Given this list of marker genes RNF5, STT3B, TSC1, SIRT1, STAT3, MYRF, CCNA2, TRPM2, SAMTOR, JAK3, AHSG, PID1, BLM, CNGA3, EXT1, PIK3R1, FCGR2B (NCBI Gene Id 2213), LY6S, ZFP36L1, ARHGEF2, SEC61B, AQP1, PTPRE, REG3G, LARP1, EGLN1, EZR, AFG2B, CRKL, PLCB1, HDAC9, OGT, SSH1, FBXW8, SLC27A1, ABCC1, EDNRB, PPP1R9B (NCBI Gene Id 84687), CASP6, IRF5, SOCS2, RALB, ADCY6, HSD11B2, CHRNA5, KANK1, C1QTNF12, NPR2, MTOR, GHR, AMFR, RYR1, NUCKS1, ERLIN1, FAM8A1 (family with sequence similarity 8 member A1), CASR, MDM2, GRIN1, KCNJ11, IFNK, AUP1, CHUK, MMP13, XRN1, SOS1, ATF6, MIR200A, ATP5PO, EEF2, RPS6KB2, FABP3, SDF2L1, CTNNB1, CHRM5, NOD2, CEBPA, PLN, IGFBP5, CD9, KCNJ8 (NCBI Gene Id 3764), TGM2, SVIP, IFNA2, APPL1, NPLOC4, TRPV1, GPIHBP1, CDK2, PDE3B, FFAR3, NDUFS4, PKD2, BMP7, CREB1, ALAS1, GRIN2A, TRPA1, PDE12, MBD5, CASTOR2, BTG1, RAPGEF3, ADCY8, CYBB, CARTPT, YWHAG, UBQLN2, TAF1, SLURP2, CSH1, IFNA8, SOX17, PRKCQ, RNF103, TMUB1, PELI1, PCNA, FOSB, CTNNA1, EDEM3, KLF16, NKX6-1, SELENOS, GPER1, TRPM4, EDEM1, IFNA14, AGTRAP, BRCA1, AQP9, HTR1B, TMEM129, PKM, RNFT1, SP1, ZDHHC7, LEP, GABRB1, BCAR1, DNAJB12, FAM114A1, EREG, IRAK3, PPP1R1B, SLC3A2, ATP2B4 (NCBI Gene Id 54594), CDH1, ZNF592, DERL2, HTR2B, GRM5, POMC, MIR140, TFF1, OAS1, IRS1, DPEP1, G6PC1, PLA2G2A, PENK, NEFL, TYK2, CHRM4, TMEM38A, OTOP1, TBC1D4, EEF2K, RGS10 (NCBI Gene Id 6001), FAF1, MAPK14, PRKAA1, INAVA, HCN2, AQP8, CAMK2A, EIF2B1, ATP2B1, RGS2, RANGAP1, CALCR, LRP5, CHRNE, ADTRP, ATF1, MYC, GPRIN3, FBXO2, PDPK1, LYN, SLC27A4, CSRP3, ITGB1, REG1A, WNT1, FKBP5, LPIN3, PDE1B, TRIM72, INS, MIR143, TLR9, PIK3C2A, TSC2, GNRHR, MIR107, REG1B (regenerating family member 1 beta), SGCB, MIR145, EIF4EBP2, RHOQ, FOXO3, RCN3, LCN2, EDN1, ACTB, OPRM1, HTR1A, YOD1, DIAPH1, PPP3CA, RNF185, TMBIM6, FBXO17, STAT2, LIPA, CDK5R1, GAL, CARD9, GNA15, MIR98, FPR2, AP3S1, GRM2, CACNG4 (calcium voltage-gated channel auxiliary subunit gamma 4), TRIM41, MAN1A2, LRP6, HTR2A, INHBA, RNLS, GALP, UBXN10, SRC (SRC proto-oncogene, non-receptor tyrosine kinase), CCL19, RAB10, GPLD1 (NCBI Gene Id 2822), RTF2, NAGK, GCK, CAD, PRKN, UMOD, BACE1, ACE, P2RY6, TOR1A, LY6H, USO1, CACNA1B, HTR3A, GRB7, APLP1, BCL2L1, AHR, AKT1, RYR2, GRB14, ERRFI1, MIR27B, GRB10, SLC26A6, PPP5C, TRIM16, IFIH1, ADRB2, AGT, CACYBP, P2RY1, HTR3D, ANKZF1, HSP90B1, HDAC6, RYR3, NPM1, FBP1, HRAS (HRas proto-oncogene, GTPase), DEFB124, TREM2, FAT1, SLC24A4, AKAP9, IFNA21, ADCY5, NOD1, HRH3, UBE2J1, PRLH, FCER1G, PKLR, AGTR1, NGFR, UBQLN1, RGS4, CRACR2A, CCR7, LPIN2, MAP3K5, BIRC2, UBAC2, GCG, SLC25A33, BAG6, DUOX2, LGMN, CHRNA1, MIR135A1, PRKCZ, UPRT, ATP1A3, RIPK2, GPX1, LRRK2, TNFAIP3, RNF145, FADD, GPD1, DHFRP1, EGR1, FAF2, TLR6, EPHB2 (EPH receptor B2), CHRNB1, SESN2, IGF2, CHRM1, CACNA1S, EIF2S1, ADA, CGAS, OS9, STAT4 (signal transducer and activator of transcription 4), HMGCS2, KCNE1, DDI1 (DNA damage inducible 1 homolog 1), RAP1B, TRIM13, ADIPOQ, SLC2A1, PQBP1, HOMER1, P2RX3, MGARP, VAMP2, NR4A2, GNAL, EPRS1, TNS2, CRH, MIR20A (microRNA 20a), EPHA4, SLC6A4, UBXN1, RETN, HTR4, PSCA, ERBIN, LPL, NUDC, DNTT, LDLR, VPS35, CASTOR3P, SCNN1G, KYNU, STAMBPL1, CEACAM1, BGLAP, NT5E, STAT5B, ERLIN2, ABCB1, ARRB2, HOMER2, DRD1, MAS1, RPTOR (regulatory associated protein of MTOR complex 1), CD68, IFNA10, PPARG, CES1, PLA2G1B (NCBI Gene Id 5319), MTARC2, TGFBR3, GDF10, KL, HNF4A, GSTP1, FDX1, FOXRED2, MC4R, MAPK1, CD4, SCNN1A, VIM, HCN1, P2RX1, PDK4, GNRH1, RGS9, GNB5, ASIC1, GOT1, NCOA1, TMX1, NPC1 (NPC intracellular cholesterol transporter 1), NR4A1 (NCBI Gene Id 93352), SLC7A5, ITGB2, CHRNA9, TYR, MAT2A, SLC9A1, SYK, PCSK9, RFTN2 (NCBI Gene Id 130132), PNPLA3, MIR146A, TNF, NPPC, CELA2A, TXN, MARCHF6, AQP11, TMEM259, RAP1BL (NCBI Gene Id 647908), ADIPOR1, PRKDC, PRKACA, LY6E, P2RY12, JAG1, SLC8A3, VWA2, MTCL2, RAD51, OSBPL8, DHX36, MYO1C, ABCA1, HTR6, PRKCD, PRNP, CLGN, SMAD3, NCK1, RNF139, AFG3L2, WNT10B, IGF1R, REN, RGS17 (regulator of G protein signaling 17), NOTCH1, SOD1, MIR92A1, SLC1A3, CIB2, RAF1, IRF3, RECQL5, VGF, DDX1, MIR4286, IFITM5, GHRHR, RHBDD1, GUCD1 (NCBI Gene Id 83606), GLDC, AGER, P2RY11, DNAJC10, TREX1, P2RX7, UCP2, SLC22A12, LTA4H, AANAT, USP19, IL1B, TMUB2, ALK, LY6G6D, CACNA2D3, JAK2, DDR2, HNRNPD, CHRM3, CHRNA2, GNRHR2, BCHE, SMARCC1, EZH2, CSHL1, LRP1, PRMT5, IFNA5, ASS1, OAS3, AIFM1, CACNA2D1, LYNX1, TXNIP, HSF1, SCAP, CHRNB3, INHBB, PARP1, MIR379, CAT, GKAP1, CUL3, IFNA1, EIF2B2, GAB1, INSR, GSTM1, TIFAB, CRTC1, MMP12, PDE4D, MIR103A1, SOCS3, PITX3, PCK2, IL2, CPT1A, TNFSF4, CYP11B2, SCN11A, PDXP, CD2AP, STC1, GNAI1 (NCBI Gene Id 2770), ERLEC1, SLC8A1, SULT1A4, KBTBD2 (kelch repeat and BTB domain containing 2), GJA1, PAK1, CD81, FBXO44, PRKCI, BORCS7, CRTC2, RBP4, TIMP1, PNPT1, DUSP1, PIK3C3, TRIM24, RAMP3, HDAC5, USP13, FOLR1, GNB1, WT1, TDO2, GRIN2D, ABL1, TOP1, PRKCA (protein kinase C alpha), TRPV4, MRGPRX1, GNAS, MEAK7, COL3A1, SNX6, P2RX5, TP53, GNA11, RRM2B, ACHE, IFNE, CYP11A1, BLOC1S6, SLC6A3, GSTM2, LDOC1, DGKQ, PALM, PTGER1, SETD2, NFKBIZ, KLF4, CDK1, TNFRSF11A, ADAMTS13, SELENON, MIR758, DUOX1, GABRB3, CASP7, NCL, SLC34A1, FOXO1, PIK3CG, STC2, EFTUD2, ABCC8, CRHBP, IFNA7, HTR3B, ALPL, UBR2, SLC2A4, INPPL1, THBD, CDH13, TIMELESS (NCBI Gene Id 8914), ST8SIA2, NR5A1, FOXP3, DHFR, GSTM3, OPRK1, MTR, UBE4B, PCK1, GABRG2, ADORA1, EN1, NCCRP1, NTRK1, DAG1, SCX, SLC2A8, RNF175, ITGA2, FUT7, GCGR, STAT5A, GLP2R, LARS1, ABAT, SORT1, LPIN1, UMODL1, MIR200C, CHRNA7, IGFBP1, UFD1, PDK2, UBXN2A, CASTOR1, KCNB1, GATA5, DRD4, P2RX2, PSEN1, DNAJB2, CFL1, AREG, NPPA (natriuretic peptide A), BSG, RAPGEF2, UBE4A, PMAIP1, TOMM70, KLHL22, C2CD5, BAIAP2, SLIT2, RARRES2, INSRR, ZBED3, MZB1, DNAI1, RIGI, SIX1, FLNA (filamin A), CITED1, CAV2, TRIM25, RHBDD2 (NCBI Gene Id 57414), IDE, ECPAS, RAB8A, RBX1, GRXCR1, GET4, CRY2, DERL1, CHRNB2, ADORA2A, STUB1, FOXC2, UBXN4 (NCBI Gene Id 23190), DAXX, JUP, JKAMP, BRSK2, LEPROT, PIP4K2B, ADSS2, PDE3A, SEL1L, SLC18A2, MIRLET7F1, UBXN6 (NCBI Gene Id 80700), NDEL1, CHMP5, CHRNG, HCFC2, RBM4, NR4A3, PTPN1, CCDC47, LARGE1 (NCBI Gene Id 9215), PTPN22, RB1, GOLPH3, SP7, COL1A1, SRD5A1, KAT2B, APOE, DENND4C, CACNB1, CANX, EIF2B5, NFKBIA, ITPR1, CHRNA6, MAPKAP1, TGFB1, INSIG1, HRH4, AKAP7, PXN, HTR2C, CSK, HRH1, KHK, TLR3, GPR173, MYO5A, CHRNA3, ALAD, KCNC1 (NCBI Gene Id 3746), SORL1, ASCL1 (achaete-scute family bHLH transcription factor 1), UBE2G2, PRKAR1A, HCN4, GH1, CDK5, PTPRJ, SRD5A2, NCSTN, GCNT1, GABRB2, RAC1, NSMCE3, NONO, SLC30A10, RANBP2, GCLC, APC, CALR, GFRAL, CPEB1, FYN, UBXN8, BCAP31, MMP19, TPR, EIF2B4, IFNA6, CSH2, PPP2R2A, MAPK3, SREBF2, RAP1GDS1, TMEM38B, CFTR, SLC5A5, MIR1271, CHRNB4, CASP3, GUCY1B1, GNAI2, EHMT2, ABCC9, P2RX4, PIP4K2A, SYAP1, SULT1A3, CYP11B1, EDNRA, PIP4K2C, DDI2, GSK3B, FOXO4, HES1, GNAO1, MIR17, CAMP, PIK3CA (phosphatidylinositol-4,5-bisphosphate 3-kinase catalytic subunit alpha), JAK1, CD40, C14orf28, STAT1, ECHDC3, CAV1, ERFE, MSTN, VCP, FLOT1, DMTN, TOP2B, VPS13C, GPR21, HM13 (histocompatibility minor 13), EIF2B3, SRSF5 (serine and arginine rich splicing factor 5), PTPN2, UFL1, TMEM67, APP, DTNBP1, CHRNA10, RNF121, GNA14 (G protein subunit alpha 14), CALM3, PER1, OXT, FBXO27, MIR302A, AGRP, UROS, RIOK3, CPS1, RAB31, LYPD1, CACNA1A, HTR3E, DDX11, NR1H4, RPL23, MIA3, GH2, HCN3, MAN1B1, DDX21, ENSG00000274276, CHRM2, SNX5, XBP1 (X-box binding protein 1), TLR4, CD36, FOLR2, CRTC3, SNCA, TYROBP, ATP5F1A, GNG2, TACR3, EIF6, NHERF1 (NHERF family PDZ scaffold protein 1), F7, TCF12, SCNN1B, IGF1, FER, SOCS1, DHX15 (NCBI Gene Id 1665), LHCGR, SLC39A14 (solute carrier family 39 member 14), STING1, IFNA16, PHIP, SIN3A, RAB44 (RAB44, member RAS oncogene family), PSMC6, MMP9, TRARG1, CPEB2, ASPH, SYVN1, HADH, RAB13, P2RX6, HTR3C, SHOC2, PTPN11, SHC1, KCNC2, SRSF6, ITGA4, UQCRC1, DNAJB9, TLR7 (toll like receptor 7), PRKCB, IFNA17, USP14, ATXN3, ADRA2A, TRPC3, AGTR2, GLP1R, GHRL, DRD2, HERPUD1, TSPO, CHRNA4, CDO1, OTC, CDC6, ATXN3L, INSIG2, MUL1, BTG2, SOCS7, ZNF106, HLCS, MAN1A1, PHEX, CHRND (NCBI Gene Id 1144), FOSL2 (FOS like 2, AP-1 transcription factor subunit), NFE2L2, SREBF1, FOS, TSHR, TUBA1A, RPS6KB1, TRIB3, KCNQ1, AGRN, CARM1, UCP3, GRIA1, CASP4 (caspase 4), DRD3, C5AR1, MMP3, COLEC12, USF1, BLVRB, KLF2, HPRT1, NLRP1, IFNB1, SPIDR, MAN1C1, CASQ2, RRAGD, MAP3K7, TICAM1, LEPROTL1, SGTA, USP25, TRAF2, HADHA, ATRX, UBE2J2, PRKCG, REG3A, SOX9, PPARA, MIR195, DERL3, CRK, P2RY4, CRY1, LONP1, IFIT1, SLC1A2, C6orf89, SEL1L2, GDF15, EP300, IL6, GATA1, STXBP3, MEF2C, CAPN10, PRKCE, STAT6, CRHR1, RPS6, ENPP1, VCAM1, JUND, CRHR2, ROCK1, IFNA4, SESN1, NCOA2, CSF2RA, BCL11A, CUL7, MAVS, GHSR, UBR1, FUT1, KAT7, RAP1A, AMIGO1, PANX1, RELA, APPL2, PIK3R2, PRMT1, KLF15, SOS2, DBH, FBXO6, CYBA, MMP2, SLC26A3, ZBTB7B, GPR82, DHX9, CA2, GNAQ, MAP1B (NCBI Gene Id 4131), HSP90AA1, PDE2A, SH2B2 (SH2B adaptor protein 2), MT-CYB, SLC1A1, PRKD1, FBN1, NCOA5, POR, IFNW1, PTK2, SHMT1 (NCBI Gene Id 9316), POU4F2, GRB2, EPG5, SMPD1, NAMPT, CBS, AKAP6, ROCK2, P2RY2, DNMT3A, CALR3 (calreticulin 3), SCNN1D, MTARC1, KDM1A, RGS8, ACTN2, HSPA5, WDTC1, MIR106B, IL10, CXCL12, COMT, CTSD, GSK3A, ZCCHC3 (zinc finger CCHC-type containing 3), AKT2, NFKB1, BCAR3, CNR2, MIR15B, MYD88, GCLM, SRSF4, RNFT2, HPCA, HDAC2, RAPGEF1, ITGB3, EDEM2, MTHFR, AHCYL1, SORBS1, ICAM1, DRD5, CDA, WFS1, PIK3R3, ACVR1C, SIK2 (salt inducible kinase 2), SOCS5, SERPINA12, CYC1 (NCBI Gene Id 1537), HTR7, EPM2AIP1, IRS4, IRS2, COL6A1, STXBP4, RFTN1, PDX1, SDK1, ITPR2, INPP5K, SESN3, CFLAR, SMPD3, GRK2, here is a description of the gene set: Any process that results in a change in state or activity of a cell or an organism (in terms of movement, secretion, enzyme production, gene expression, etc.) as a result of a nitrogen compound stimulus. Human Gene Set: GOBP_RESPONSE_TO_NITROGEN_COMPOUND species: Homo sapiens